The following is a description of a gene set: The change in morphology and behavior of a CD8-positive, alpha-beta T cell resulting from exposure to a mitogen, cytokine, chemokine, cellular ligand, or an antigen for which it is specific. species: Mus musculus Mouse Gene Set: GOBP_CD8_POSITIVE_ALPHA_BETA_T_CELL_ACTIVATION, and this is the list of marker genes: Satb1, Igtp, Hfe, Otud5, Mapk8ip1, Gpr18, Lilrb4b, Bcl2, Cd244a, Cd274, Gimap1, Vsir, Crtam, Slc4a2, Cbfb, Runx1, Clec4a2, Tox, Nckap1l, Lilrb4a, Tnfsf8, Dapl1, Ptpn22, Wdfy4, Sh3rf1, Zbtb7b, Socs1, Clec4a3, Irf1, H2-T23, Xcl1, Pax1, Clec4a4, Psmb11, Runx3, Ifng (interferon gamma), Eomes